The following is a description of a gene set: Genes up-regulated in comparison of macrophages exposed to L. donovani versus macrophages exposed to T. gondii. Human Gene Set: GSE360_L_DONOVANI_VS_T_GONDII_MAC_UP Monocyte-derived dendritic cells (DC) and macrophages (MΦ) generated in vitro from the same individual blood donors were exposed to five different pathogens, and gene expression profiles were assessed by microarray analysis. Responses to Mycobacterium tuberculosis and to phylogenetically distinct protozoan (Leishmania major, L. donovani, Toxoplasma gondii) and helminth (Brugia malayi) parasites were examined, each of which produces chronic infections in humans yet vary considerably in the nature of the immune responses they trigger. studied in species Homo sapiens from publication Chaussabel D, Semnani RT, McDowell MA, Sacks D, Sher A, Nutman TB (PMID 12663451), and this is the list of marker genes: KCNIP4, PRPF3, TNIK, ACADVL, SRP54, TMEM184B, RNGTT, SAPCD1, BLTP1, AQP3, KRT75, IRGC, MYO7A, SERPINB2, WDFY3, TFF2, DTX4, RRN3, VCAN, VNN2, TXNIP, KDELR2, LASP1, GML, ENTPD1, DAB2, MBTPS2, PAX2, KPNA6 (NCBI Gene Id 23633), SERPINB13, PPM1H, R3HCC1L, LDLRAD4, DOC2B, HTR1E, AOAH, ZFR2, TRIM58, SERPINE1, LZTR1, PIP, PLK3, OAZ2, CCT6B, AMPD3, DCHS1, BANF1, MCC, NR1H3, NDUFS2, ERBB2, ATP5PB, TRPC6, TRPM1, ST3GAL6, CRYGD, TNFSF14, SELENOP, TBKBP1, PDHX, RAB11FIP5, NBR1, HK2, ORC4, CTNNBIP1, SUN1, ZNF185, BAAT, PFKFB1, FKBP2, LAMB3, AKAP8, CDK2AP2, LBX1, TRIO, ZNF280A, PNLIPRP2, CCL13, PAK5, CHD1L, SLA, ZNF202, LAPTM4A, DENND5A, DAD1, BCL2L1, GIP, USH2A, SPHK2, PLA2G2A, PDPN, URB2, ZBTB25, RHOA, SMYD5, TLN2, ANXA5 (annexin A5), FABP3, CLDN14, F2R, ALDH1B1, ADCY8, ZNF629, KIAA0232, LTA4H, MOB1A, MPZL1, ACP2, MFSD5, NRF1, PLA2G1B, CCDC22, TTLL4, ALDH3B1, MAGI2 (NCBI Gene Id 9863), GALK2, SUPT4H1, MYOZ2 (NCBI Gene Id 53348), DNAH7, NUDT21, PRCP, CTNNB1, SSH1, TLK2, FMO2, ACOX1 (acyl-CoA oxidase 1), GCM1, ARVCF, MPHOSPH8, SPART, SDS, TKTL1, PTAFR, HSPB6, GLOD4, KLF10, SERINC1, ABCA4, SDHB, RNF103, ZFP37, CHRNA4, TUBA1A, HTR2B, IDH1, CACNG1, PCOLCE, CLBA1, GRAMD1B, PENK, BLCAP (BLCAP apoptosis inducing factor), PDIA4, AGTR2, ARPC3, AHNAK, LY86, PIK3CB, MGP, BLVRA, LRRC37A2, MLLT3, OMD, MUC3A, INSIG1, CALCOCO1, CCSER2, VASH1, CPM, PTK2B, KCNA3, APBA2, TRAM2, PPIF, PPBPP2, KDELR3, KMT2A, HSPA5, CD163, FCHSD2, S100P, ASF1A, IL1B, HCG4B, CCR1, THOC2, CAPN7, IGHA1, ATP9B, FCGR3A (Fc gamma receptor IIIa), ITPKC, TAB1, GABARAP, HMOX1, SNTB1, CD9, HCLS1, MAP4K5, MISP, MIR124-1HG